Given this list of marker genes MED1, AREG, TGFB1, PHB2, WNT5A, here is a description of the gene set: The beginning of development of the breasts in the female. studied in species Homo sapiens Human Gene Set: GOBP_THELARCHE